Given this list of marker genes SLC12A8, CAMK4, ZBTB44, NIF3L1, ISL1, SLC39A6, ILDR2, PHC3, IGSF3, CCDC186, B3GALT2, CLN8 (NCBI Gene Id 619435), RANBP6 (RAN binding protein 6), CYP27C1, ILRUN, NFAT5, TEP1, CLMN, RMDN1, CERT1, CENPA, SEZ6L, CREB5, RUNDC3B, OPALIN, MFSD6, COBLL1, LYZL1, EIF2B1, MLLT10, G3BP2, PHLDA1, EEIG2 (EEIG family member 2), UGT3A1, SSPN, MAGEA11, SCML4, RPP14, PLCL2, BIN3, ST8SIA1, CTDP1, BSN, ATAD2B, APOL6, PDGFRA, UBE2Q2, LCE1B, LRRC10B, THSD4, LYZL2, PADI3, RCC2, NOL6, GALNT11, ODAPH, SLC35A3, BRD3, FOXJ2 (NCBI Gene Id 55810), TMEM164, AAR2, NTN1, ARRDC3, TYMSOS, PLAGL2, CNOT6L, MYO18B, MSTN, WNT2, CYP4A22, DSP, EIF5, FOXE3, TRIM39, TIPIN, ENTPD7, ZNF99, NAA11, TNPO1, C14orf132, MAPRE1, EPN2, RASGRP2, ITGA8, AFF4, FGFR2, KCNA4, IL1R1, PLEKHB2, DLG2, ABL2, ABLIM3, TMEM52, EFCAB2, APLN, here is a description of the gene set: Human Gene Set: MIR5695 species: Homo sapiens from publication Chen Y, Wang X (PMID 31504780) Genes predicted to be targets of miRBase v22 microRNA hsa-miR-5695 in miRDB v6.0 with MirTarget v4 prediction scores > 80 (high confidence targets).